Given this list of marker genes Scn10a, Scn4b, Scn2b (sodium channel, voltage-gated, type II, beta), Scn3b, Scn5a, Scn1b, here is a description of the gene set: Enables the transmembrane transfer of a sodium ion by a voltage-gated channel through the plasma membrane of a cardiac muscle cell contributing to the depolarization phase of an action potential. A voltage-gated channel is a channel whose open state is dependent on the voltage across the membrane in which it is embedded. studied in species Mus musculus Mouse Gene Set: GOMF_VOLTAGE_GATED_SODIUM_CHANNEL_ACTIVITY_INVOLVED_IN_CARDIAC_MUSCLE_CELL_ACTION_POTENTIAL